The following is a description of a gene set: Binds to and stops, prevents or reduces the activity of an acetylcholine receptor. studied in species Homo sapiens Human Gene Set: GOMF_ACETYLCHOLINE_RECEPTOR_INHIBITOR_ACTIVITY, and this is the list of marker genes: LYPD6, LY6H, LY6S, LYNX1, LYPD1, LY6E, SLURP2, LY6G6D